Given this list of marker genes SKIL, BOK, RNF183, SIRT1, SIAH1, PLAGL2, IL20RA, MIR15A, EIF5A, PRKRA, EI24, MYC, RIPK3, CAV1, FBXW7 (NCBI Gene Id 55294), UBB, FLCN, RPS7, RACK1 (NCBI Gene Id 90938), BID, SFPQ, PMAIP1, MCL1, IL19, BAD, TAF6, RPL26, VNN1, NCK2, SOD1, CLU, GSDME, MMP2, MSX1, TP73, BBC3, S100A9, PTPN2 (NCBI Gene Id 5771), MIR27B, DDIT3 (DNA damage inducible transcript 3), BCLAF1, BAX, NHERF1, S100A8, PIAS4, RAD9A, FBH1, MIR186, NKX3-1, STYXL1, NOX1, SERINC3, TP53BP1, ADCY10, MTCH2, RPS3, NCK1, BCL2L11, PARK7, BCAP31 (NCBI Gene Id 10134), BECN1, MIR16-1, FIS1, NUPR1, LCK, SEPTIN4, TP53, NACC2, here is a description of the gene set: studied in species Homo sapiens Human Gene Set: GOBP_POSITIVE_REGULATION_OF_INTRINSIC_APOPTOTIC_SIGNALING_PATHWAY Any process that activates or increases the frequency, rate or extent of intrinsic apoptotic signaling pathway.